Given this list of marker genes NOSIP, PRKN, OXA1L, GLA, DRD5 (dopamine receptor D5), GZMA, MT3, PRDX5, NT5DC2, here is a description of the gene set: Human Gene Set: GOBP_NEGATIVE_REGULATION_OF_OXIDOREDUCTASE_ACTIVITY studied in species Homo sapiens Any process that stops or reduces the rate of oxidoreductase activity, the catalysis of an oxidation-reduction (redox) reaction, a reversible chemical reaction in which the oxidation state of an atom or atoms within a molecule is altered.